Given this list of marker genes Flad1, Slc52a3, Acp5, here is a description of the gene set: electronically inferred by orthology from the curated human pathway part of: Metabolism of water-soluble vitamins and cofactors This event has been computationally inferred from an event that has been demonstrated in another species.<p>The inference is based on the homology mapping from PANTHER. Briefly, reactions for which all involved PhysicalEntities (in input, output and catalyst) have a mapped orthologue/paralogue (for complexes at least 75% of components must have a mapping) are inferred to the other species. studied in species Mus musculus Reactome Pathway: Vitamin B2 (riboflavin) metabolism